The following is a description of a gene set: species: Mus musculus The formation of specific regional progenitor domains along the dorsal-ventral axis in the developing forebrain. Mouse Gene Set: GOBP_FOREBRAIN_DORSAL_VENTRAL_PATTERN_FORMATION, and this is the list of marker genes: Six3, Fgf8, Pax6, Gsx2, Gli3, Nkx2-1, Ttc21b